Given this list of marker genes IRAK2 (NCBI Gene Id 3656), SELP, TGFBR2, PPP1R13B, FBXO25, ENOX2, CD82, ARMC10, ZFAND6, TRAM2, PSTPIP1, HPS5, DCAF4, CIART, FBXO8, DDB2, GALNT11, SPTBN1, CIC, TMEM176B, CHD2, NPC2, GOLGA1, ARMCX3, PADI2, ZSWIM4, PGLYRP2, IFT172, ADAMTSL4, LTO1, RALBP1, ETV6, GPR180, RPL5 (NCBI Gene Id 90045), RBM5, MAP3K1, SNAPIN, DNAJC5, SCARB2, ARMCX6, TAF9B, IL1R2, CREB3L2, STAM, NPC1, MRTFB, GPRASP1, RIPK2, SPATA1, COG4, EIF3E, RAD52, RRAGD, GPR146, TBC1D20, CCR5, ACOX1, GRB7, NXN, CCNDBP1, AQP9, PPOX, ULK1, ATP6V0D1, STXBP2, RICTOR, MMP12, POLI, MOS, TCF25, RRAD, IGFBP4, NT5C3A, BBS9, PTPN12, HMG20A, TMCO6, UVRAG, MTA3, ZNF579, PATJ, ARRDC2, ERCC4 (ERCC excision repair 4, endonuclease catalytic subunit), MED13L, SNX20, LDHD, SERPINF1, ARHGAP45 (Rho GTPase activating protein 45), TEC, COQ8B, UPF2, RANBP9, SLC49A4, ETNK1, PGAM1, KREMEN1, FAM117A, CLK4, RBM48, TAPT1, CCNL1 (NCBI Gene Id 57018), CEPT1, VMP1, TNFSF9, PTK2B, MYO7A, GOLPH3L, PJA1, NUFIP1, GM2A, ESM1, SBNO2, HSPA1B, PRPF39, ARAP1, CHD7, ALDH1B1, MSL1, SF3B1, EXOC6, ARMC7, PADI3, HJURP, MAP4K2, MTMR14, SNX32, GPR174, LYSMD3, KDSR, SNAPC1, BLOC1S6, UNKL, NBR1, FAM193B, LMBRD1, CPSF6, BMAL1, MMS19, BTBD7, FGL2 (fibrinogen like 2), CXCR4, HTT, SIGIRR, LIME1, NFE2L2, CSNK1G1, NEB, TRAK1, ITPR3, SOCS3, LGALSL, CTSE, ETFDH, CDKAL1, GOT1, PTPRA, ENSA, COG5, ZNF708, OAZ2, LPP, PLEKHO1, CD84, RINL (Ras and Rab interactor like), TMEM121, NUMA1, TMEM167B, LONRF2, CCNT2, FUCA1, COL5A2, ECM1, HERC1, LRRC28, COPZ1, PPP1R15A, DCAF11, LRRC58, TNFAIP8, KDM5B, MAPK3, PRKD2, MSRA (NCBI Gene Id 4482), HLX, DUBR, LMNTD2, NCOA4, ADAMTS10, SSR3, PPME1, HLTF, ELMOD3, MEAK7, RNF215, LEMD1, SUSD3, TXNDC16, TRPV2, CNST (NCBI Gene Id 163882, consortin, connexin sorting protein), EPC2, here is a description of the gene set: from publication Liu PT, Stenger S, Li H, Wenzel L, Tan BH, Krutzik SR, Ochoa MT, Schauber J, Wu K, Meinken C, Kamen DL, Wagner M, Bals R, Steinmeyer A, Zügel U, Gallo RL, Eisenberg D, Hewison M, Hollis BW, Adams JS, Bloom BR, Modlin RL (PMID 16497887) Genes down-regulated in monocytes: untreated versus M. tuberculosis 19 kDa lipopeptide (24h). Human Gene Set: GSE8921_UNSTIM_0H_VS_TLR1_2_STIM_MONOCYTE_24H_DN In innate immune responses, activation of Toll-like receptors (TLRs) triggers direct antimicrobial activity against intracellular bacteria, which in murine, but not human, monocytes and macrophages is mediated principally by nitric oxide. We report here that TLR activation of human macrophages up-regulated expression of the vitamin D receptor and the vitamin D-1-hydroxylase genes, leading to induction of the antimicrobial peptide cathelicidin and killing of intracellular Mycobacterium tuberculosis. We also observed that sera from African-American individuals, known to have increased susceptibility to tuberculosis, had low 25-hydroxyvitamin D and were inefficient in supporting cathelicidin messenger RNA induction. These data support a link between TLRs and vitamin D-mediated innate immunity and suggest that differences in ability of human populations to produce vitamin D may contribute to susceptibility to microbial infection. species: Homo sapiens